The following is a description of a gene set: Mouse Gene Set: CUI_CDC1_IFNK_RESPONSE_UP from publication Cui A, Huang T, Li S, Ma A, Pérez JL, Sander C, Keskin DB, Wu CJ, Fraenkel E, Hacohen N (PMID 38057668) Genes positively differentially expressed in cell type: cDC1 (conventional dendritic cell type 1) upon treatment with cytokine: IFN-κ in mouse lymph nodes in vivo. studied in species Mus musculus Cytokines mediate cell-cell communication in the immune system and represent important therapeutic targets. A myriad of studies have highlighted their central role in immune function, yet we lack a global view of the cellular responses of each immune cell type to each cytokine. To address this gap, the authors created the Immune Dictionary, a compendium of single-cell transcriptomic profiles of more than 17 immune cell types in response to each of 86 cytokines (>1,400 cytokine-cell type combinations) in mouse lymph nodes in vivo. A cytokine-centric view of the dictionary revealed that most cytokines induce highly cell-type-specific responses. For example, the inflammatory cytokine interleukin-1β induces distinct gene programmes in almost every cell type. A cell-type-centric view of the dictionary identified more than 66 cytokine-driven cellular polarization states across immune cell types, including previously uncharacterized states such as an interleukin-18-induced polyfunctional natural killer cell state., and this is the list of marker genes: Chmp4b, Trim30d, Txn1, Ube2l6, Irf7, Lap3, Ifit2, Pml, Ptms (parathymosin), Isg15, Rac1, Stat1, Actr2, Crip1, Irf5, Snx2, Stat2, Ifi205, Epsti1, Phf11d, Anxa1, Scarb2, Slfn2, Pttg1, Psmb10 (proteasome (prosome, macropain) subunit, beta type 10), Sfr1, Mndal, Ifi211, Ms4a6c, Ogfr, Samhd1, Dnaja2, Prdx1, Spi1, Plekho1, Ostf1, Ifi204, Tspo, Sct, Ppa1, Ywhag, Herc6, Rnf213, Ccnd3, Zbp1, BC035044, Selenow, Phf11a, Tmbim6 (NCBI Gene Id 68309), Oasl2, Bst2, Atp6v1d, Oas3, Bag1, Akr1a1, Eif2ak2, Xaf1, Grn, Nmi, Pkib, Trim30a (NCBI Gene Id 20128), Ifi207, Tpm4, Calm1, Dhx58, Dck, Ifi35, Plac8, Lgals3bp, Selplg, Acadl, Ly6e, Uba7, Ifi44, Twf2, Irf8, Pnp, Ms4a6b, Srsf7, Npc2, Parp12, Frmd4a, Sdc3, Cxcl9, Atf1, Fdps, Cd47, Slc8b1, Sp100, Isg20, Hmgn3, Taldo1, Ccdc86, Casp4, Cycs, Usp18, Mx1, Pfkp, Aida, Asb2, Svbp, Shisa5, Psmb9, Phf11b, Phyh, Anxa5, Nampt, Pgap2, Ifi209, Csrp1, Ubc (ubiquitin C), Ms4a4c, Irgm1, Cct3, S100a6, Marchf5, Rsad2, Anxa7, Lgals9, Bri3, Ccnd1, Lgals3, Tmsb10, Atp6v1g1, Rnh1 (ribonuclease/angiogenin inhibitor 1), Ly6c2, Tagln2, Slfn5, Mpp1, Cnp, Gnl3, Ifi203, H2-T23, Ifitm3, Serpina3g, Ifi47, Sumo1, Id2, Helz2, Ifih1, Bbx, Dpy19l1, Dnaja1, Psma4, Ly6a, Sp110, Hspa8